Given this list of marker genes Rpl10a, Fbxl15, Rnf170, Slc22a5, Smtnl2, A530072M11Rik, Aagab, Ip6k1, Sclt1, Pmepa1os, Ppil6, Asap1, Spsb1, Fzd4, 4930589L23Rik, Tcf7l2, Stat5b, Cdh22, Ptpn3, Rplp0, Rpl36al, Ppp4r1, Nt5c1a, Bag2, Hunk, 4632427E13Rik, Ldb1, Resf1, Plekhd1os (pleckstrin homology domain containing, family D (with coiled-coil domains) member 1, opposite strand), Rasl11a, B230112G18Rik, Plcb3, Cuedc1, Mrpl14, Fam20b, Skp2, 2410022M11Rik, Fahd1, 4930426L09Rik (NCBI Gene Id 74629), Zbtb44, Tmem126b (NCBI Gene Id 68472), Kras, Sync, Igf2, Ankib1, Gse1, Trp73, Nudt19, Slc15a4, Lpar1 (lysophosphatidic acid receptor 1), Snord68, Map3k12, Gsn, Dlgap4, Cic, Slc25a23, Gm9530, Relt, Sav1 (salvador family WW domain containing 1), Pnpla8, Miga1, Tle2, Clec4g, Osgin2, Map3k5, Atp2a2, Naa30, Adam11, Gm27003, Dapk2 (death-associated protein kinase 2), Insig1, Usf2, Tert, Arf3, Snord58b, Rcc1, Fbxw7, Gm15559, Zfp385c, Azin1, Msl2, Amfr, 4930535L15Rik, Gm20109, Frrs1l, Rbmxl1, Mettl25b, Nubpl, Iqgap2, Macroh2a1, Ovol1, Scube1, Aebp1, Mir1199, Ndufa1, Mtss1, Zbtb24, Hook1, Ints13, Efna4, Gpr153, Zfand5, Mmp9 (matrix metallopeptidase 9), Usp1, Wapl (WAPL cohesin release factor), Pias3, Fem1b, Rsad1, Ssc4d, Pura, Ccl25, Rfx5, Icmt, Igf2os, Aak1, Lig4, Recql, Nr4a2, Axin2, Rabgap1, Mir219c, Cdkn2a, Map3k4, Pdzd2, Tbl1xr1, 2810013P06Rik, Usp43, Akap13, Avl9, Magi3, Tgfbrap1, Pxn, Fbxw11, Bfar, Flywch1, Cd63, Cfap298, Litaf, Macf1, Mt3, Map3k1, Fndc3a, Cep68, Slc6a20a, Pdp1, Rabep1, Peli1, Ercc4, Tanc1, Ocln, Tubg1, Kbtbd7, Tarbp2, Abat, Hmg20b, Glul, Crocc, 2810025M15Rik, Snora73a, Golt1b, Gm10419, 4732491K20Rik, Ube2v2, Rab3b, Ggps1, Atp4a, Apbb1, Dusp2, 9530036O11Rik, Patj, Thbs1, Arid4a, Ubxn2a, Spc25, Mast4, Trip12, Pole, Eeig2, Ebag9, Ube2d3, Hecw2, Nsun6 (NCBI Gene Id 74455), Osbp2, Aebp2, Degs1, Bloc1s6, Kat6b, Vangl1, Celf2, Pwwp2b, Tshr, She, Ccdc106, Hdgf, Fgfrl1, Itm2c, Cbfa2t3, 4930558J18Rik, Hoxa1, Prrt1b, Ss18l1, Vipr2, Tox, Vldlr, Evi5, Lcorl, Dyrk1a, Fam131c, Foxp1, Fut8, Brd10, Mrpl13, Plekhm3, Pcsk4, Ube2q1, Rap1gap, Arhgdig, Slc35c1 (NCBI Gene Id 228368), Zic2, Gm9970, Gm12764, Slc35a3, Syncrip, 2010001A14Rik, Pcgf5 (NCBI Gene Id 78660), Exoc5, Nr3c2, Npepps, Mir6392, Prkch, Egln1, Hoxd13, Cbx2, Rimklb, Igf1r, Gm11772, Mad2l1, Cyren (NCBI Gene Id 78412), Ercc2, Cpm, Mir129b, Mcam, Top2b, Zfp184, Dll3, Eps8l2, Strn4, Gm6420 (NCBI Gene Id 623356), Stx3, Ppm1m, Slc35c2, Cln8, Celf5, Svil, Slc45a3, Npdc1, Bahd1, Ap5m1, Als2, Cnih2 (cornichon family AMPA receptor auxiliary protein 2), Mmab, Kif13a, Dnajb14, Ift25, C230096K16Rik, Pcyt1a, 9330162012Rik, Gm13284, Npr2, 8430432A02Rik, Mybl1, Jpx, 2610037D02Rik, Epb41l4b, Sergef, Pitx3 (paired-like homeodomain transcription factor 3), Snhg3, Zdhhc3, Msantd5l, Gm15704, Mrps33, Exosc7, Cpeb3, Cenpw, Trerf1, Sptbn4, 2310068J16Rik, Celsr1, Irx3os (NCBI Gene Id 319388), 2610206C17Rik, Coq6, Gm2788, Il10rb, Pex5, Camsap2, Mafb, Epm2aip1 (NCBI Gene Id 77781), Myo5a, Ccdc136, Usp6nl, Gbx1, Slc22a21, Slc35d1, Ebf3, Lsm14a, Snx5, Nt5e, Rbpms, Psd, Foxf1, Sgpl1, Dnajc1, Rassf8, Maged1, Fbxo2, Alg11, Dlg4, Nkx2-2, Trim14, Trnp1, Rasal2, Sdhaf2, Mdfi, Gpatch11, Trappc10, Eepd1, Slain2, Coq2, Dnaaf9, Elovl1, Tspan9 (tetraspanin 9), Map4k2, Gm336, Pgpep1, Ascl4, Arid4b, Cxcl16, Rnft2, Prkar2b, Gfi1, Pmepa1, Itpk1, Rprd1a, Nfatc1, Rcbtb1, Cacng2, Dap, Rnf39, 4930503L19Rik, 2810030D12Rik (RIKEN cDNA 2810030D12 gene), Mir219a-1 (NCBI Gene Id 723823), Mn1, Gm11973, Tulp1, Khk (ketohexokinase), Eogt, Disc1, 4731419I09Rik, Usp49, Rai1, Tusc2, Mapk8, Aarsd1, Frmpd1, Xk, C430014B12Rik, Nexn, Pdzd8, 9530080O11Rik, Zkscan6, Ano6, Atn1, Fhad1, Smg1, Adcy9, Zbtb7b, Iqch, Shisa7, Gm11586 (predicted gene 11586), Pgbd5, Cd164, Fendrr, Srfbp1, Tns3, Txndc5, Bbip1, A430072P03Rik, Notch3, Cpne5, Bloc1s6os, E130114P18Rik, Zfp131, Matcap1 (NCBI Gene Id 74356), Hagh, Ice1, Gfra1, Casz1 (castor zinc finger 1), Gm23301, Sesn1, Ptprk, Gm15283, Mdga1, 1700016A09Rik, Lamtor5, Hook3, Gpbp1, Col23a1, Yipf2, Alyref, Nacc2, Mef2c, 4632404H12Rik, 1500002C15Rik, Pou3f3, Taf6, Homer1, Ptch1, Kctd18 (potassium channel tetramerisation domain containing 18), Hoxb3 (NCBI Gene Id 15410), 4933406I18Rik, Gm10687, Chd5, 2010110E17Rik, Zfp536, Nhsl3, Misp3, Plcd1, Cracdl, Gpat3, Abcd3, 1110038F14Rik, Hcn1, Aifm3, Crtc3, H3c8, Ddr1, Runx2os1, Gm20033, Gabarapl2, Nuak2, Gm15706, 2610306M01Rik, Cnpy4, Garem2, Mir9-3hg, Emid1, Kdm7a, Fads1, Pip4k2a, Cyth2, Ywhab, Trim71, Leprotl1, Ccdc92b, Hlf, Gm20732, BC034090, Greb1, BC028777, Gadd45g, 1700123M08Rik, 0610038B21Rik, Dvl3, Gm10658, Ankrd6, Bcl11b, Lhx6, Orai2, Gm16731, Gsdme, Apc, Gm12992, Fbxo44, Tspan2, Sipa1l3, Fgfr1op2 (NCBI Gene Id 67529), Tmem151a, Snora24, E230001N04Rik, Fndc5, Btg2, Il6ra, Elovl2, Scaf4, Hebp1, Wnt5b, Cpne7, Bcar1, Hectd1, 9330111N05Rik, 9330154J02Rik, Dlx1, 3110056K07Rik, Tfap2a, Fam187b, Dhps, S1pr5, Mir7687, Dazap1, Rexo2, Pkn2, Snhg8, Tapt1, Hpca, Plec, Faap20, Ppp1r35, Rab30, Cdc42se1 (CDC42 small effector 1), Fgd4, Lmo2, Gng5, Luzp1, Adm, Akap9, E2f8, Ei24, Phldb2, Cdc42bpa, Syt2, Mir3083, Cited2, Mir129-2, Cd276, Hapstr1 (HUWE1 associated protein modifying stress responses), Lhfpl6, 4930405A21Rik, Ring1, Fam98c, Foxj1, Bmal1, 4930449I04Rik, Mtmr4, Chd7, Zfp110, Spry1, Cldn7, Crot, Ep400, Fndc3b, Gng12, Jade2, Stard6, Smurf2, Mir6236, Sp3, Rbm43, Sh3pxd2b, Slc25a11 (solute carrier family 25 (mitochondrial carrier oxoglutarate carrier), member 11), Tent4a, Prmt3, Tbr1 (NCBI Gene Id 21375), Gm15327, 4930597O21Rik, E130102H24Rik, Mir203, Krit1, 9630001P10Rik, Ppt2, Ccno, Smpd2, Rap1b (NCBI Gene Id 72733), Rpf1, Il18r1, Dnm2, Fgr, Fgf9, Gm5577, Lrrc42, D130043K22Rik, Sap30l (NCBI Gene Id 50724), Gm5475, 4930539J05Rik, Ism2, Dpp8, 5730522E02Rik, Kbtbd8os, 2610035F20Rik, Dbndd2, H2-T5, 1700001G11Rik, Epc1, Fam222a, Myo6, Gm26608, Gm10190 (NCBI Gene Id 791338), 9330151L19Rik, Mpp3, E2f3, Cux2, Kdelr3, Tead3, Gm6658, Pfdn6, Zfp704, Rpl13, Marveld2, Atp7b, Gm15912, Frmd4a, Tjp1, Ero1b, Dst (dystonin), Edf1, Teddm2, Spns2, Ddah2, Gm13986, Pik3ca, Isg20l2, D3Ertd751e, Tshz3, Agk, Camk1d, Dmbx1, Epc2, Jakmip1, Pkdcc, Kremen2, A730013G03Rik, Hace1, Brca2, Zfand2a, Gm15564, Ttc34, Dhrs1, Ddx31, Tmem64, Tmem135, Gm14285, Fam124a, Rubcn, Ube2q2, Dpp4, Dipk1b, Wsb2, Pxmp2, Slc37a2, Hrh3, Cep57l1, Slc35a1, Grhl1, Srsf4, Mphosph6, Ube4b, Snord13, Ccne2, Zmynd15, Tada2b, Rnf167, Snapc2, Dusp15, Dcdc2a, Prickle4, Cdk12, Golm1, Gm15408 (NCBI Gene Id 100503307), Mier1, Nol4l, Mpc2, Fat4, Tmem63a, Adgrl2, Dstn, Tgfb3, Zfp422, Arsi, Runx2, Arhgef28, Adamts14, Cdyl, Pax6, Nfix, Rbm38, 2700049A03Rik, Snrk, Mtmr10, Pde7a, Ssbp3, Cnot6l, 4930583K01Rik, Ankrd63, Faxc, Agap1, Mllt10, Bahcc1, Mindy1, Dock3, Acvr1, Setbp1, Carhsp1, Pcbp3, Tent4b, Zbtb14, Ltbp1, Wdr87-ps, Klf11, Rad18, Adrm1, Gnas, Samd15, Akt1, Upp2, Plcb4, Akap11, Mgme1, Wdr46, Fam184b, Mff, Sgk1, Mllt11, Gm13063, Ubtf, Slc38a2, Dleu2, Eeig1, Scrt1, Tmem230, Gata5, Gypa, Gm20467, Cnnm1, Nsmaf, Lhfpl2, Fam53c, Tbx15, Mtbp, Bcap29, Ptar1, Zswim6, Gnal, Septin9, Socs6 (suppressor of cytokine signaling 6), Snora73b, Ago1, Msi1, Dnmt3b, Ccdc85c, Pierce2, Inpp4b, Gpr162, Xrcc3, Mllt1, Fgf18, Eaf2, Kcnj12, Pros1, Adcy3, Slc38a1, Carmil3, Ppara, Ptp4a1, Gabbr1, Syce2, Zfp36l2, Nol3, Tfrc, Gar1, Mir7240, Fam161b (NCBI Gene Id 217705), Fgl2, Enpp4, Rffl, St6galnac6, Fkbp5, 9130017K11Rik, Ldha, Wnk2, Htra4, Skic3, Fdx2, Kcnj4, Dlx1as, Gpr4, Cdh1, here is a description of the gene set: Mouse Gene Set: BCOR_TARGET_GENES species: Mus musculus from publication Yevshin I, Sharipov R, Kolmykov S, Kondrakhin Y, Kolpakov F (PMID 30445619) Genes containing one or more binding sites for (Bcor) in their promoter regions (TSS -1000,+100 bp) as identified by GTRD version 20.06 ChIP-seq harmonization.